The following is a description of a gene set: species: Mus musculus Mouse Gene Set: GOBP_CYTOPLASMIC_TRANSLATION The chemical reactions and pathways resulting in the formation of a protein in the cytoplasm. This is a ribosome-mediated process in which the information in messenger RNA (mRNA) is used to specify the sequence of amino acids in the protein., and this is the list of marker genes: Rps8, Eif3j2, Rpl10a, Dhx9, Eif3m, Rps13, Eif4h, Cpeb3, Gm6133, Rpl23a, Eif2b5, Pkm, Rps3a1, Rpl36-ps12, Unk, Rpl36, Rpl14, Rpl13, Eif4ebp1, Eif2s3x, Rps17, Eif3g, Slbp, Rpl35a, Rps12, Rps25, Ybx1, Rpl26, Rpl39, Rpl19, Rpl6l, Rps16, Eif4a2, Rps6, Rpl39l, Paip1, Eif3i, Rps26, Rps27a, Cpeb2, Rpl31, Igf2bp1, Rplp2, Rps14, Cpeb1, Ncbp2, Hnrnpd, Eif3k, Rps18, Rps5, Eif3d, Rpl23, Rpl15, Rpl32, Rbm4, Rps7, Rpl18, Cpeb4 (NCBI Gene Id 67579), Akt2, Eif2s3y, Eif3l, Rps28, Rpl36a, Rps3 (NCBI Gene Id 52418), Mettl3, Eif2b3, Eif2b1, Rwdd1, Hnrnpu, Rpl27, Zfp385a, Eif3f, Rplp0, Rpsa, Rpl27a, Rpl37a, Rpl37, Dhx36, Eif3e, Rpl17, Eif3h, Lin28a, Rps4x, Nmnat2, Alkbh3, Rps23, Rpl11, Rpl27rt, Rps2, Mif4gd, Eif5, Drg1, Cnbp, Parp16, Sh3bgrl, Rpl8, Rps15, Piwil2, Sars1, Nemf, Impact, Eif4a1, Nck1, Rps21, Eif3j1, Smyd5, Rpl38, Rpl5, Eif2ak4 (eukaryotic translation initiation factor 2 alpha kinase 4), Rps6-ps4, Aars1, Rps20, Eif3b, Fau, Rps19, Rpl3, Eif2d, Ckap5, Rpl13a, Mcts2, Eif3c, Rpl6 (ribosomal protein L6), Rpl9, Rpl30, Rpl22l1, Eif2b2, Syncrip, Uba52, Denr, Piwil1, Rps29, Rps10, Etf1, Zcchc13, Rpl7a, Rplp1rt, Mcts1, Rplp1 (NCBI Gene Id 80450), Eef2, Csde1, Eif2s2, Rpl9-ps6, Eif2b4, Rpl18a (ribosomal protein L18A), Rpl22, Gtpbp1, Ythdf2, Rpl4, Eif3a, Pkp1, Rbm24, Pabpc1, Rpl28, Rpl32l, Rpl41, Ftsj1, Rpl29, Drg2, Eif4b, Rpl21, Rps11, Fmr1, Rpl24, Rpl7, Rps24, Rps15a, Ncbp1, Rpl35, Dhx29, Rpl34, Rps9, Rpl12, Zc3h15